Given this list of marker genes Apoc3, Lpl, Lipc, Apoe (apolipoprotein E), Lcat, Nr1h4, Gpihbp1, Apoa5, Apoa4, Apoa2, Apoa1, here is a description of the gene set: The acquisition, loss or modification of a protein or lipid within a triglyceride-rich lipoprotein particle, including the hydrolysis of triglyceride by lipoprotein lipase, with the subsequent loss of free fatty acid, and the transfer of cholesterol esters to a triglyceride-rich lipoprotein particle by cholesteryl ester transfer protein (CETP), with the simultaneous transfer of triglyceride from a triglyceride-rich lipoprotein particle. Mouse Gene Set: GOBP_TRIGLYCERIDE_RICH_LIPOPROTEIN_PARTICLE_REMODELING studied in species Mus musculus